Given this list of marker genes KCNT1, DEPDC5, CABP4, CRH (NCBI Gene Id 1392), CHRNA4, CHRNB2, CHRNA2, here is a description of the gene set: Focal hyperkinetic seizure A focal seizure characterized at onset by predominantly proximal limb or axial muscles producing irregular sequential ballistic movements, such as pedaling, pelvic thrusting, thrashing, rocking movements. studied in species Homo sapiens Human Gene Set: HP_FOCAL_HYPERKINETIC_SEIZURE